Given this list of marker genes SLC9A1, PLSCR1, EREG, MX1, PLAUR, MARCHF6, THBS1, TSC22D2 (TSC22 domain family member 2), OAS3, TRMT2B, ISG15, IFIT1, LSM5, IRF7, CCN1, PLA2G6, ZEB1, ERBIN, IFI6, here is a description of the gene set: Human Gene Set: XU_HGF_TARGETS_INDUCED_BY_AKT1_6HR Genes changed in DU-145 cells (prostate cancer) in the absence but not presence of a dominant negative form of AKT1 upon exposure to HGF for 6 h. The cytokine scatter factor (SF) (hepatocyte growth factor) transduces various biologic actions, including cell motility, invasion, angiogenesis and apoptosis inhibition. The latter is relevant to understanding the role of SF in promoting tumor cell survival in different contexts, for example, detachment from basement membrane, growth in metastatic sites and responses to chemo- and radiotherapy. Previously, we showed that SF protects cells against apoptosis owing to DNA damage, by a mechanism involving phosphoinositol-3-kinase/c-Akt signaling. Here, we used DNA microarray assays to identify c-Akt-regulated genes that might contribute to cell protection. DU-145 human prostate cancer cells were transfected+/-a dominant-negative mutant Akt, treated+/-SF and analysed for gene expression using Affymetrix arrays. These studies identified SF-regulated genes for which induction was c-Akt-dependent vs -independent. Selected microarray findings were confirmed by semiquantitative and quantitative reverse transcription-polymerase chain reaction. We tested the contribution of four SF-inducible/c-Akt-dependent genes (AMPD3, EPHB2, MX1 and WNT4) to protection against adriamycin (a DNA topoisomerase IIalpha inhibitor) using RNA interference. Knockdown of each gene except EPHB2 caused a small but significant reduction in the SF cell protection. The lack of effect of EPHB2 knockdown may be due to the fact that DU-145 cells contain a single-mutant EPHB2 allele. A combination of three small interfering RNAs blocked most of the protection by SF in both DU-145 and T47D cells. These findings identify novel c-Akt-regulated genes, some of which contribute to SF-mediated cytoprotection. species: Homo sapiens from publication Xu J, Gao M, Fan S, Meng Q, Goldberg ID, Abounader R, Ressom H, Laterra JJ, Rosen EM (PMID 17099727)